Given this list of marker genes MT-CO3, CACNA1S, FDX2, HADHB, MLIP, DMD, PGAM2, COQ2, PGK1, PHKG2, HADHA, PYGM, RYR1, LDHA, ALDOA, PFKM, FKRP, MT-CO1, LPIN1, TANGO2, ANO5, PHKG1, PHKA1, CRPPA, CPT2, PHKA2, HADH, OBSCN, ISCU, ACADVL, PHKB, SGCB, here is a description of the gene set: species: Homo sapiens Human Gene Set: HP_MYOGLOBINURIA Presence of myoglobin in the urine. Myoglobinuria